Given this list of marker genes LIFR, FMN1, OTUD7B, ATP2B4, ZHX1, DDIT4L, CLIP4, CRYZ, ACSL6, KCTD18, SDHD, GMCL1, ARID2, ZFP36L1, PYROXD1, ETS1, DCAF7, MIER3, UBTF, OPTN, SHC3, SAMD9, GLCCI1, SRSF6, PGM3, NFAT5, PLEKHG3, MARCO, UPP2, TMTC1, AFAP1L1, SCD5, CNR1, ZCCHC3, CSRNP2, RBM39, ZC3HAV1, C2orf76 (chromosome 2 open reading frame 76), PRKRA, NIPSNAP2, TAGAP, CELF5, PSMB5, NEK9, here is a description of the gene set: Genes predicted to be targets of miRBase v22 microRNA hsa-miR-27b-5p in miRDB v6.0 with MirTarget v4 prediction scores > 80 (high confidence targets). studied in species Homo sapiens Human Gene Set: MIR27B_5P from publication Chen Y, Wang X (PMID 31504780)